The following is a description of a gene set: The series of molecular signals in which an intracellular signal is conveyed to trigger the apoptotic death of a cell. The pathway is induced in response to hydrogen peroxide (H2O2). Human Gene Set: GOBP_INTRINSIC_APOPTOTIC_SIGNALING_PATHWAY_IN_RESPONSE_TO_HYDROGEN_PEROXIDE species: Homo sapiens, and this is the list of marker genes: MAP2K4, PINK1, PARK7, MIR92A1, PDCD10, STK25, MIR133A1, AKT1, TRAP1, RACK1